The following is a description of a gene set: The chemical reactions and pathways involving folic acid, pteroylglutamic acid. Folic acid is widely distributed as a member of the vitamin B complex and is essential for the synthesis of purine and pyrimidines. species: Homo sapiens Human Gene Set: GOBP_FOLIC_ACID_METABOLIC_PROCESS, and this is the list of marker genes: FPGS, DHFR2, MTRR (5-methyltetrahydrofolate-homocysteine methyltransferase reductase), SLC46A1, DHFR, MTHFD2, MTHFD2L, ALDH1L2, FOLR1, PM20D2, MTHFD1, SHMT1, SLC25A32, SLC19A1, MTHFS, DHFRP1